Given this list of marker genes HLA-G, MIR20B, SIRT1, CGAS, MIR217, TP53, MIR22, YPEL3, MIR10A, KRAS, MIR34A, PAWR, B2M, MIR146A (NCBI Gene Id 406938), ABI3, EEF1E1, KIR2DL4, MORC3, ARG2, here is a description of the gene set: Any process that activates or increases the frequency, rate or extent of cellular senescence. Human Gene Set: GOBP_POSITIVE_REGULATION_OF_CELLULAR_SENESCENCE species: Homo sapiens